Given this list of marker genes MAP3K13, CD34, SPARC, BRI3, F2, IGDCC3, MIR328, CYP27A1, NKX2-1, GBX1, IFNA5, TMEM184A, GOLT1A, SYNDIG1L, PDLIM4, ITPKA, CHRNB3 (cholinergic receptor nicotinic beta 3 subunit), SCN1B, SLC39A2, SLC6A8, TFEB, CYP2S1, PHLDA2, CLDN11, SATB2, CRYBG1, DEGS2, MDGA1, OVOL3, JPH4, TM4SF4, ITGA1, SRL, GALNT10, TMEM221, PRKN, KRT36 (keratin 36), ABCA4, GARIN4 (NCBI Gene Id 149647), PCGF2, TRPM8, SYCE2, CRX, CLXN (calaxin), TBX18, FA2H, TRIB1, CWH43, CARMIL3, FGF1, AGER, TRIB2, MIR30D, KRT34, JADE1, AMPD1 (adenosine monophosphate deaminase 1), ARMCX1, MRPS24, SCARF2, DMRT3, PMP22, BOLA2, DDX19B, KCND3, H1-7, KIF26B (kinesin family member 26B), KCNK9, NTSR1, HDGFL1, STRN, PIM2, CLGN, FLCN, GPRC5C (NCBI Gene Id 55890), TSPAN10, HCN4, KRT35, FZD6, PRODH (proline dehydrogenase 1), EPCAM, NDRG4, CBLN2, TRIM47, CATSPERB, GDNF, TMEM14C, NEK3, SERPINA10, PITX1, MGP, ANKRD50, FAT3, EGR3, DLEC1, NRG1, PDZD2, CRAT, HPS6, CORT, ADPRHL1, FAM135B, PLD6 (NCBI Gene Id 201164), RASL10B, NKX2-5, RASA3, ALPG, GPC5, SLC18A3, TGFBR1 (transforming growth factor beta receptor 1), TMEM139, SLC6A5, PRSS45P, ZBTB7C, GSTM2, ARHGAP19 (NCBI Gene Id 84986), CXCL17, S100A7A, CAPZB, HSPG2, ARSI, SERINC5, RAB44, ZC2HC1A, ELN, SIPA1L1, SYCP2L, ZIC2, PDYN, RGS13, CNGA1, RAC3, GRM5, IL6ST, CRACR2A, BTD, DUSP8, KCNJ4, EPHX4, TEKT4, FSTL5, PTCRA, GLOD5, RAB38, TGIF2, TRIM15, MIR211, here is a description of the gene set: Genes up-regulated in T reg: wildtype versus DICER1 knockout. species: Homo sapiens from publication Zhou X, Jeker LT, Fife BT, Zhu S, Anderson MS, McManus MT, Bluestone JA (PMID 18725525) A new Treg-specific, FoxP3-GFP-hCre BAC transgenic was crossed to a conditional Dicer knock-out mouse strain to analyze the role of microRNAs (miRNA) in the development and function of regulatory T cells (Tregs). Although thymic Tregs developed normally in this setting, the cells showed evidence of altered differentiation and dysfunction in the periphery. Dicer-deficient Treg lineage cells failed to remain stable as a subset of cells down-regulated the Treg-specific transcription factor, FoxP3, while the majority expressed altered levels of multiple genes and proteins (including Neuropilin 1, GITR and CTLA-4) associated with the Treg fingerprint. In fact, a significant percentage of the Treg lineage cells took on a Th memory phenotype including increased levels of CD127, IL-4, and interferon-g. Importantly, Dicer-deficient Tregs lost suppression activity in vivo; the mice rapidly developed fatal systemic autoimmune disease resembling the FoxP3 knockout phenotype. These results support a central role for miRNAs in maintaining the stability of differentiated Treg function in vivo and homeostasis of the adaptive immune system. Human Gene Set: GSE11818_WT_VS_DICER_KO_TREG_UP